Given this list of marker genes Eif4e2, Ncbp3, Eif4g1, Eif4a2, Ncbp2, Eif4e (eukaryotic translation initiation factor 4E), Eif4g2, Ncbp1, Eif4e1b, Otud6b, Eif4e3, Eif4g3, Eif4a1, here is a description of the gene set: Mouse Gene Set: GOCC_RNA_CAP_BINDING_COMPLEX species: Mus musculus A protein complex that binds to an RNA cap structure to mediate RNA processing and/or translation initiation.